Given this list of marker genes ZNF684, PSMD9, LCIIAR (lung cancer immune cell infiltration associated lncRNA), NME3, FGF3, BAX, LY96, KLHL4, VSTM4, ZBTB12, NDN, LINC00857, EMP3, SPTBN4, ZNF321P, GNB1, MUC5AC, RBMY3AP, SLC22A11, SSR4, BTD, MYH16, ZNF853, RBM8A, PTPRZ1, PKM, PADI3 (NCBI Gene Id 51702), SLC18A2, ILVBL, HCST, CD109, SEC14L5, STYK1, SLC16A3, CTSW, TBC1D10A, RASGEF1A, PMS2P9, C9orf85, GPR65, PCDHA3, MT2A, HYCC2, RASL11B, CHPF, SGSM3, TSR3, P4HB, GATA3, COQ8B, TMEM229B, GPR55 (NCBI Gene Id 9290), AP3S1, NLRP11, KCNJ11, PDE4D, RHOJ, DANCR, NKX3-2, MYH6, PSORS1C3, CELF4, KCNJ16, PNCK, DRAXIN, ID4, MRPS28, MADD, MYL12B, PTPN13, TNF, GPR6, PPP1R14A, CPSF1, MRPL24, TAS2R50, THNSL1, ROR2, DGAT1, LCN1, CCDC81, HMGB3P22, FURIN, PCBP4, FANK1, WEE1, HPGD, GALK2, PPM1G, MYL1, ATPSCKMT, NFASC, MICOS10, EVA1B, TAF13, LAX1, SELENBP1, TAMALIN, CAMK1, FAM78B, RAPGEFL1, EFHC2, MGAT4C, MROH2A, CHMP6, MRPL58, ADK (adenosine kinase), SALL1, PXMP2, SEC14L3, REC114, DPYSL3, IGFL1, TLR9, OPRPN, ZMYM5, IL17RC, FAM181B, SNTG1, NPHS1, WDR88, PSMA7, ABCB8, TNNI3K, POSTN, C12orf75, MGAT2, VAMP5, RALY, NKX6-3, GET4, MRPS7, MZT2B, PRDX1, HAPLN4, GATAD2A, OTOP2, STMN3, ADARB1, PTGDS, PHF5A, HOPX, SPAM1, SYNJ2, GCHFR, GAS8-AS1, TMEM119, PNPLA3, ADGRE3, RPS5, CYTH2, GMPPB, ADAMTSL4-AS2, HRH1, ASL, ZDHHC11, ACY3, ELOA, FHDC1, GPS2 (NCBI Gene Id 2874), P4HA3, DBN1, SMDT1, SIRT2, PLK3, P2RX7, OAF, TRIM36, TBX22, PSMB8, STX4, MYBPC1, PCGF3-AS1, GXYLT2, EHBP1L1, S100A10, SLC1A1, NTAQ1, RUNX3, MRC2, PLEKHG1, KREMEN1, CILP2, SPMIP11, CCDC65 (coiled-coil domain containing 65), H1-2, SNED1, GRAP2, ARL6IP4, PSMD14, here is a description of the gene set: from publication Chevalier N, Jarrossay D, Ho E, Avery DT, Ma CS, Yu D, Sallusto F, Tangye SG, Mackay CR (PMID 21471443) Genes up-regulated in comparison of CD4 central memory T cells versus CD4 CXCR5+ T cells. species: Homo sapiens Human Gene Set: GSE26928_CENTR_MEMORY_VS_CXCR5_POS_CD4_TCELL_UP